The following is a description of a gene set: Human Gene Set: GOMF_CULLIN_FAMILY_PROTEIN_BINDING Binding to a member of the cullin family, hydrophobic proteins that act as scaffolds for ubiquitin ligases (E3). species: Homo sapiens, and this is the list of marker genes: KLHL36, ASB2, ANAPC11, RBX1, DCUN1D4, BTBD1, DCUN1D3, KCTD17, CCDC22, KCTD9, DCUN1D1, KCTD6, RNF7, KLHL3, DCUN1D2, PRKN, KLHL13, KCTD21, KCTD2, KCTD5, DCUN1D5, DDB1 (NCBI Gene Id 1642), KLHL9, GMCL2, SKP1, KLHL21